Given this list of marker genes SYNGAP1, RAB5A, ACP4, FMR1, JPH3, CLN3, CAMK2G, SYAP1, RAB8A, DLG4, CNTN2, RAB3GAP1, SYT4, GRIN2D, SNCA, SHANK3, CAMK2D, NETO1, RASGRF1, RAC1, SYP, GRIN2A, CAMK2B, FXR2, NEURL1 (neuralized E3 ubiquitin protein ligase 1), GRIN2C, GRM5, SHISA8, NPTN, APOE, ZDHHC2, MCTP1, SHISA6, SYNGR1, KMT2A, PPFIA3, DBN1, GRIK2, NOG, EPHB2, GRIN1, KRAS, SHISA9, ARC, APP, DRD2 (dopamine receptor D2), GSG1L, HRAS, NCDN, GRIN2B, NF1, RAB11A, SLC8A2, CAMK2A, S100B, NSMF, RAB3A, FXR1, KIT, KCNJ10 (potassium inwardly rectifying channel subfamily J member 10), SLC4A10, here is a description of the gene set: Human Gene Set: GOBP_REGULATION_OF_NEURONAL_SYNAPTIC_PLASTICITY studied in species Homo sapiens A process that modulates neuronal synaptic plasticity, the ability of neuronal synapses to change as circumstances require. They may alter function, such as increasing or decreasing their sensitivity, or they may increase or decrease in actual numbers.